Given this list of marker genes SMS, BAP1, PEPD, SCARF2, SPART, ACSL4, SDHD, LRIF1, AP1B1, WNT3, VAC14, WARS1, PROP1, PTDSS1, MET, OCA2, METTL27, PPARG, KRT14, NPR2 (NCBI Gene Id 4882), CHST14, KIDINS220, COQ7, CDK10, TCAP, RTN2, RPL13, CBL, GALNT2, MUC5B (mucin 5B, oligomeric mucus/gel-forming), SPTLC1, MSH4, STX16, MTMR14, SEM1, FMR1, SOS2, ITGB6, PPP2CA, ARSB, MRPS28, HSPG2, MSL3, GMNN, RASGRP1, TCF12, TYROBP, FANCC, HLA-DRB1, WNT4, PALB2, FLVCR1, SLC34A3, SEMA3E, HYAL1, H3-3A, PEX2, PRIM1, SOX4, LIG3, SHANK3, IFT140, DSE, RFWD3, CD244, PEX16, RB1, HPGD, H19, MAPRE2, FTO, QRICH1, SNRPN, CREB3L1, AKT3, NUP133, PTPN22, ASXL1, NEB, MTOR, IL2RA, POC1A, SIAH1, MEGF8, LAMA2, GIPC1, CHRNG, CRLF1, PPP3CA (protein phosphatase 3 catalytic subunit alpha), DUX4, EXOC6B, SULT2B1, UBAP2L, PACS1, SOX9, RTEL1, CYP26B1, VPS33A, SETD1B, APC2, NTRK1, CRPPA, RNF216, NHS, ADAMTS10, CD96 (CD96 molecule), RECQL4, TRIP13, DNAJC30, EPB41L1, GTPBP2, LAMB2, LAMB3, CNOT3, KCTD1, GATA1, SLC35A3, FGFR3 (NCBI Gene Id 55546), TMCO1, PSAP, RNU4ATAC, PHF21A, PDE4D, TP63, SPIDR, AFF2, UFD1, POGLUT1, SPTLC2, BUB1B, LBR, LDB3, COL9A3, GFPT1, BBIP1, SMOC1, BRD4, FIG4, MAP1B, SMAD6, SEMA5A, B2M, DDX6, GJA1, BMPR1A, MYH11, KDSR, KCNN3, GNPTAB, KDM5A, NBAS, ADNP, RPS20, PRX, HSD17B4, COLEC10, TNFRSF11A, ALG6, PIGL, MKRN3, SIK3, CCDC28B, CFTR, TP53RK (TP53 regulating kinase), OSGEP, RPL35A, BMP2, DSTYK, PPP2R3C, TLK2 (NCBI Gene Id 11011), CPLANE1, TUBB2B, PRR12, JAG2, CAST, DYNC2H1 (NCBI Gene Id 79659), ARID1B, PYROXD1, PAFAH1B1, EOGT, ECE1, IDUA, POMT2, FOXP1, IFT74, IFT52, SH2B1, IFT81, MTFMT, KLLN, LTBP4, MIR17HG, LAMC2, FAM149B1, ECEL1, FLNC, MEN1, PEX3, LFNG, SPG11, LUZP1, TBL1XR1, AIP, SLC9A6, GRHL2, POFUT1, MAP3K20, CSGALNACT1, WDR73, TMEM70, B9D1 (B9 domain containing 1), BICRA (NCBI Gene Id 29998), COX4I1, CREBBP, MAPK8IP3, TDO2, TOR1AIP1, CDH3, CTNNB1, SLC10A7, FBLN1, ATG7, CCND2, SC5D, SUFU, RAI1, FBXO38, CLIP2, BGN, KCNJ5, DKK1, ALOX12B, KIAA0586, TNPO3 (transportin 3), CACNA2D1, GYG1, FXN, SMN2, CHD1, PHF6, EIF4H, SMARCB1, FGF9, ARHGAP31, TUBB3, MYPN, PIGF, KIAA0753, PORCN, SLC25A46, TOGARAM1, KRT83, NOG, PIGY, BMPR1B, RNU4-2, MB, KAT6A, POLG2, CTSC, EVC2, TBL2, PIK3CD, CCNQ, BLM, COL25A1, MYL2, EIF2AK3, ZEB2, ASH1L, EXTL3, UPF3B (UPF3B regulator of nonsense mediated mRNA decay), BRF1, NFKBIL1, PPOX, DLX3, LRP4 (NCBI Gene Id 4038), NSD2, TPR, TGFB3, MKKS, SRRM2, TNFRSF1B, RPGRIP1L, POMT1, CEP104, RIT1, IFT172, ARHGEF2 (NCBI Gene Id 9181), TRAPPC9, GNE, GATAD2B, DPAGT1, WAC, FKBP6, SOX11, CSPP1, STIM1 (NCBI Gene Id 6786), RPL35, NUP37, TPM2, EFNB1, ABCA12, EXOSC5, WRAP53, ERCC5, COG8, DNMT3B, BCOR, CEP41 (centrosomal protein 41), SOX18, GNAI1, VPS35L, TRIM32, RELN, GPR101, ANKLE2, STAG1, CNTN1, U2AF2, NR5A1, SASH1, TAF4, SERPINF1, TNR, NEXMIF, SLC12A6, SCN1B, PIGH, KCNK4, NEUROD2, C2CD3, PSMB4, RPS28, AIFM1, MADD, UBR7, HDAC6, TBX1, GJB6, SCN1A, AFF4, TBC1D24, PDK3, VPS33B, DYNC1H1, TGFB1, FGFRL1 (fibroblast growth factor receptor like 1), EBP, PIGS, CLDN16 (claudin 16), RUNX2, SLC5A6, GNB1, PTPN11, NPHP1, RAB11B, HSPB1, RRAS2, SLC35B2, CCDC8, DOCK6, IHH, STUB1, TTN, PYCR2, WDR35, DLG5, GJB4, LORICRIN, SF3B2, CLCN3, ALG12, SLC22A4, PCYT1A, MECOM, BIN1, FTSJ1, BBS12, ACTA1, HNRNPDL, CIBAR1 (NCBI Gene Id 730572), DEAF1, CNTNAP1, SMARCC2, LTBP3, CADM3, BAZ1B, HOXA11, KMT2D, SCN2A, MIR140, KRT5, RPS7, CUL3 (NCBI Gene Id 8452), IPO8, TMEM147, ROBO1, CAMTA1, FLNA, BRCA1, EMD, NEPRO, CPT2, BRIP1, ZSWIM7, EMG1, COL6A3, BPTF, NHP2, NKX2-5, PHYH, SCUBE3, CDKN1C, GP1BB, IQSEC2, NPM1, DPF2, AP1G1, SFRP4, INPPL1, BSCL2, ATRIP, RPGRIP1, SEPTIN9, MYSM1, PTEN, TAT, NOTCH1, ALS2, IRX5, PWAR1, TMEM94, NIN (NCBI Gene Id 57681), FARSA, TRIM37, PRKAR1A, ADAMTSL1, PEX13 (NCBI Gene Id 5194), VPS51, RNF13, CLCN7, GABRA3, ALX1, GMPPA, BPNT2, DHCR24, RAD51, SUPT16H, HDAC8, GUSB, IGF1R, EXOSC2, IFT27, GNAS-AS1, ERCC1, CPLX1, G6PC3, PEX7, SIM1, PARN, RPL9, PEX5, BMP4, IFT122, KDM6A, AMMECR1, ASXL3, SLC35D1, POLG (NCBI Gene Id 5428), COL5A1, LIG4, TBCK, TUBB, NR4A2, COL9A2, SCNM1, TRAPPC2, RPS10 (ribosomal protein S10), KRT6C, SMAD4, SMC5, RETREG1, GLA, PRKCZ, MEGF10, ANAPC1, TXNDC15, TNNT3, CD28, POLR1A, PAPPA2, RASA1, MED12, SAMD9, BANF1, KCNJ11, TYMP, DNM2, UFC1, CTSD, NAA20, KAT6B (lysine acetyltransferase 6B), MTHFS (NCBI Gene Id 10588), SNORD115-1, PDHA1, SIL1 (SIL1 nucleotide exchange factor), TRIM8, SKI, USP9X, SUZ12, DLG4, PIBF1, SRCAP, LAMA5 (laminin subunit alpha 5), PAH, TWIST2, SHOC2, FRA10AC1, KLHL40, MYF6, TMEM231, SERPINB7, ALMS1, VPS37A, AGPS, SGCD, PDXK, CEP57, RPS6KA3, TRAPPC11, KL, NDN, MUSK, SLC25A24, TSEN34, TUBA1A, DLK1, COX14, KIF22, UBE2T, SLX4, FANCG, POP1, OBSCN, NEFL, NCF1, CHN1, ABHD5, GJA8, RPL18, RPL31, MCTP2, ATR, RIN2, SMARCD1, DSC2, NEK1, PEX6, CNOT2, GABBR2, TFG, SH3PXD2B, MYH7, ARL13B, ASAH1, ACTG1, EXT1, DUX4L1, DDHD2, RERE, PEX14, DEPDC5, LEMD3, COPB1, RSPRY1, DHODH (dihydroorotate dehydrogenase (quinone)), EED (NCBI Gene Id 8726), OPA1, MT-TE, CD55, KRT74, PHEX, NEK9, SF3B4, MESP2, CHUK, GPR35, MACROH2A1, GRIN1, YY1AP1, KRT6A, ATP6AP2 (NCBI Gene Id 95880), DYNC2LI1, TRRAP, PRKG2, HYLS1 (NCBI Gene Id 50957), CST6, DPM1, PKP1, GNAQ, EFL1, KIF7, MEFV, ITGA7, BMP15, WNT10A, PRKACB, FANCD2 (FA complementation group D2), TNFRSF11B, HMBS, PEX1, PTPN6, SPTAN1, MCOLN1, ABCA3, ASPH, SEMA4D, GLMN, HIC1, CCDC88A, CRKL, SLCO2A1, HESX1, KPTN, RPS27, COL27A1, CD4, PPP1R13L, GSC, MORC2, KIAA0319L, DSP, XYLT2, SBDS (SBDS ribosome maturation factor), WNK3, ALDH6A1, PI4KA, DYNLT2B, CDK5, POLRMT, DCTN1, PAK3, ARCN1, TBX4, KDF1, LAGE3, AP4M1, BTRC (NCBI Gene Id 8945), BRAF, GRIK2, GPKOW, SLC52A2, SDHB, SP7, POLA1, STAG2, HOXA13, ADAMTS17, REEP1, PLEKHG5, INPP5E, MYLK, NELFA, PPP2R1A, CLDN11, NUP107, RAC1, ATP6V0A2, TFE3, KLHL41, GARS1, AFF3, RAB34 (NCBI Gene Id 83871), NXN, SETD5, CDC6, COL12A1, FBXW4, SMN1 (NCBI Gene Id 91918), CCN6, NEDD4L, GPC3, SIN3A, ZSWIM6, SEC24C, RNF2, TBC1D2B, YWHAE, SOST, SLC6A9, RAB3GAP2, MBTPS1, EGR2, TIMM8A, B4GALT7, SGCG, PRKD1, MTX2, LMBRD2, HIRA, TRPM3, KCNAB2, PSENEN, SNIP1, BUB1, SLURP1, CTNND2, PIK3R2, CCDC32, ITGB4 (NCBI Gene Id 3691), GJB3, ADAMTSL2, LZTR1, PKDCC, ASPN, IFT80, SACS, TOE1, RAB33B, COL6A2, CD247, CHRNE, PPP1CB (NCBI Gene Id 5500), RTL1, HARS1, RAPSN, MAN1B1, TGM1, GALC, TRAF7, KDM4B, GNAS, EFEMP1, MYCN, MMP9, TFAP2A, NEFH, CLPB, LIFR, LTBP1, TGM5, ASNS, ATP2A2, FANCM, PNPLA1, KIF15 (kinesin family member 15), KCNJ8, CDH11, FGFR1, MST1, PUM1, TBCE, YY1, MYMK, PRKAR1B, TPM3, HMGA2, TOR1A, VPS37D, POR, ZNF462, CWC27, EPS15L1, EP300, CDKL5, BUD23, ZNF668, SYNE1, HUWE1, EXT2, GORAB, LETM1, AKT1, CENPE, DMP1, PLOD1, FOXP2, PDE6D, TWNK, GHR, WDR11, NALCN, ZNF141, SCAPER, DST, PHIP, BMP6, FERMT1, DLX4, ERCC2, NKAP, PIGG, JPH1, DNA2, SHOX, KLF13, SATB1, ALDH18A1, CDK19, PMM2, GJB2, PTH1R, MOGS, NARS1, LRBA, RPL8, COL9A1, PEX10, ZIC1, LYSET, CHST3, TRIO, PRG4, ZMYM3, SMC3, WDPCP, H4C3, MPZ, ALX3, IL2RB, APC, ATP11A, IARS1, GDAP1, PIGP, NUP88, ESCO2, NOTCH2NLC, DVL3, EFEMP2, EIF2S3, SLC9A1, LZTFL1, WIPI2, IRF6, JARID2, SPRTN, CITED2 (Cbp/p300 interacting transactivator with Glu/Asp rich carboxy-terminal domain 2, NCBI Gene Id 154106), DLL3, SLC25A4, FBXL3, SIGMAR1, SNRPB, LIPE, MTPAP, DPYD, SCN9A, UNC80, MAGEL2, PIK3R1, TBX2, SLC34A2, FANCE, ALG9, HEPHL1, GDF5, ATAD1, RFX7, SMARCA4, CDC45, RPS23, USB1, BBS1, PGM2L1, TSEN54, OBSL1, RASA2, CEP19, MATR3, DLL4, ORC1, SFTPC (NCBI Gene Id 6440), SCN4A, RIGI, YRDC, IFT56, PLAA, RPL5, WASHC5, TLL1, RSPO2, PEX26, NSD1, CEP290, HHAT, GABRD, CAVIN1, VCP, RAD21, WWOX, KNSTRN, FCGR2A, ACAN, NRAS, IL11RA, NOTCH2, CCNK, CAV1, MARS1, GAN, CASZ1, EIF2AK4, ACTL6B, COL2A1, SPRED2, KDM1A, LMNA, AEBP1, MAP2K2, SEPSECS (NCBI Gene Id 51091), TTC21B, INTU (NCBI Gene Id 27152), L1CAM, NDUFB11, EFTUD2 (elongation factor Tu GTP binding domain containing 2), TCF4, LRP5, PEX12, KRT6B, HNRNPA1, KANSL1, FKRP, CDSN, CYP27A1, FLG, PITX1, POMP, FGD4, SBF2, TRMT10A, KCNE5, KRT85, SOX5, NDRG1, CYP4F22, AGO2, FIBP, GNAO1, MMP1, PIGB, SFTPA1, SPECC1L, SELENON, ALG13, AGA, MPV17, ZDHHC9, NAA60, ERF, DYNC2I2, COG4, HIVEP2, SMAD3, ORC4, PLOD3, ERI1, AK9, BBS2, COLEC11, ACVRL1, MAP3K7, UFSP2, SLC6A17, ARL6IP6, WLS, RECQL, H4C9, TMEM67, MYH8, RYR3 (NCBI Gene Id 6263), MEG3, SVBP, HMGCR, TPRKB, ANO5, USP7, SYNE2, NFIX, TMEM216, BAG3, PRRT2, RREB1, ITCH, FANCL, SMO, ROR2 (receptor tyrosine kinase like orphan receptor 2), ZNF292, TBR1, MAF, TRPS1, SOX6, NAA10, DLX6, PGAP2, IKBKG, LAMA3, MAT2A, IGF2, CHD7, FBN2, CHRNA1, FBXO28, PWRN1, SLC39A8, FANCI, PYCR1, CTSK, DPYS, ARX, PIGQ, GLB1, KCNH1, ARVCF, GATA4 (NCBI Gene Id 2626), RBM8A, MITF, HOXD13, NUP85, VWA1, KDELR2, LMX1B, PLIN4, COL7A1, SMAD2, SRY, DNM1L, TRPV4, KMT2A, CFAP418, RUSC2, LAS1L, ITPR3, GABBR1, RPL10, ADGRG6, POLR3H, TWIST1, WDR37, MRPS22, PROKR2, IFIH1, BMP1, TBX3, CHSY1, FDFT1, AGPAT2, POU1F1, ARID2, FOXE3, PIGO, HINT1, ANKRD55, KRAS, TFAP2B, ZNF469, RPL15, RMRP, GLE1, LARS1, TYMS, SPEN, OPA3, PHF8, RUBCN, SLC26A2, HNRNPH2, DPP9, KATNIP, CEP120, REV3L, PNPLA6, FRG1, EHMT1, RPS26, CACNA1A, GATA6, FANCA, DYNC2I1, ZBTB20, MECP2, HYOU1, AQP5, KDM6B, HFE, IDS, PLEC (plectin), ADH5, MAX, GPC4, FGFR2, FKBP10, LMBR1 (NCBI Gene Id 85501), MAPK1, WNK1, CUL4B, ATP7A, PAICS, TINF2, BBS5, CHRND, CBY1, RPL27, KRT1, MSX2, PAX3, FZD2, NCKAP1L, ABCC9, NF1, IRF5, SPARC, TGFBR2, SPTBN1, FN1, NSUN2, NOD2, DYSF, CPOX, TREX1, GNA11, CLCN5, KIF5C, PIK3C2A, GMPPB, CKAP2L, ERCC6, HK1, RAB3GAP1, MLIP, IL6ST, CHD8, PLAG1, FAT4, PIGV, RHBDF2, PIK3CA, HEPACAM (NCBI Gene Id 220296), SLC39A13, ADAMTS15, TCTN3, RIPK4, IQCE, ENPP1, TGFBR1, OTUD5, GTF2I, CWF19L1, SNAP29, FBLN5, CSNK2A1, GJB1, GNB4, TGDS, PTF1A, SVIL (NCBI Gene Id 6840), TMEM270, CIITA, COASY, SLC29A3, KRT10, PTPRF, DPH2, NAA80, MFAP5, NKX2-6, CEP152, EDA2R, ANXA11, TRPV3, IGF1, OCRL, DMXL2, DGCR2, EMILIN1, PRMT7, KLHL15, EIF4A3, TAPT1, GNPNAT1, TBX22, CTSB, GPC6, STN1, CAV3, BLTP1, VPS13B, CTC1, ZNF699, GATA2, KLHL24, ADAMTS3, SATB2, TMEM237, MTM1, INSR, TNNI2, EYA1, RAB23, GRB10, CYP7B1, DVL1, NFASC, RBM28 (NCBI Gene Id 55131), GATA5, USF3, SIK1, CANT1, EDA, KIFBP, MMP13, UBE4B, OTUD6B (OTU deubiquitinase 6B), DONSON, H3-3B, MYBPC1, JAG1, PHOX2A, NTNG1, TIA1, NKX3-2, STXBP1, IFITM5, STAMBP, KIF21A, NIPBL, COL14A1, C19orf12, HES7, PCDHGC4, PRDM5, MATN3, SLC9A7, DSG1, DOK7 (NCBI Gene Id 619409), FGF16, MT-CO3, ATL3, RAC3, SHMT2, NPR3, DGCR8, ASXL2, IL21, TASP1, CLP1, COL1A2, ZNF423 (zinc finger protein 423), PGAP3, PIGT, MYOD1, SHH, ADA2, SPEG, NONO, FILIP1, DHX16, NOP10, ACTB, XYLT1, SLC35C1, TMEM138, LMNB2, RPS15A, PEX11B, DYM (NCBI Gene Id 54808), P3H1, TERC, TRAIP, ADSS1, GNB2, COL11A1, SDHC, B3GALT6, B3GAT3, CLIC2, CDC42BPB, SFTPA2, SUCLG1, PMP22, KMT2E, PDPN, GGCX, FAM50A, CERS3, PRKDC (protein kinase, DNA-activated, catalytic subunit), ADAT3, TCTN2, HTT, CTLA4 (NCBI Gene Id 3411), PDE3A, WASF1, EZH2, PSTPIP1, COL11A2, KLK11, ATP13A2, SMARCA2, RYR1 (NCBI Gene Id 906), ELN, GRM7, MFN2, GPX4, MEF2C, MYH2, CYP27B1 (cytochrome P450 family 27 subfamily B member 1), NUP188, UBE3B, HRAS, ZMPSTE24, SCYL2, BUB3, GDF1, KATNB1, ALG14, DHCR7, ST3GAL5, KY, MRAS, SLC18A3, ATRX, ESS2, ALG2, CNOT1, SMCHD1, RTTN, DOCK3, TBX5, ERGIC1, COX7B, HS2ST1, AHDC1, KANK2, MED13L, ARPC4, CDC42, SPG7, GNS, SLC52A3, PNPLA2, ZC4H2, SCLT1, SNUPN, WDR4, WDR81, CC2D2A, TTC8, COG6, DNAJB6, GLYCTK, COL13A1, CHRNB1, TMEM53, CHST11, ACBD6, RPS24, ZMYM2, WNT5A, IDH2, EMC1, GLI1, CAPN3, FGF10, ALOXE3, SON, PSMC3IP, ADAMTS2, WFS1, LOX, SERPINA12, VDR, WRN, CFL2, BICD2, EXOSC9, COMT, SLC32A1, KBTBD13, TSEN15, GTF2IRD1, COL5A2 (NCBI Gene Id 1290), FANCB (FA complementation group B), IARS2, SLC25A12, RPL11, TAF6, ARMC9, FGD1, NLRP3, RPS29, MED25, PCNT, HSPB3, TUFT1, TOPORS, PPM1D, MGAT2, KRT17, ACTG2, DMD, HECTD4 (HECT domain E3 ubiquitin protein ligase 4), CDT1, AAGAB, RAF1, ATN1, TNNT1, MKS1, ERLIN2, SYT2, ARL3, FHL1, CUL7, WNT7A, ATP2B1, GLI3, CRIPT, TMEM222, LARS2, SLC2A10, NECTIN1, ITPR1, FGF23, SNORD116-1, RBPJ, SLC25A21, THSD4, GDF11, IL10, STS, COL10A1, DHPS, HEY2, TMEM218, MME, MMP23B, COL1A1, ARID1A, ALDH1A2, SOS1, SALL1, SMARCAD1, MBTPS2, PCGF2, DNAJC21, CHRNA7, ATP6V1B2, B9D2, TGFB2, SEC23B, PAX1, HERC1, SLC35A2, ZNHIT3, NGLY1, MAP2K1, PTCH1, MIA3, DPYSL5, PNKP, KCNJ2, RIPPLY2, MYL11, FRAS1, COL17A1 (NCBI Gene Id 7828), CHD4, SMG9, ABCC8, AGGF1, MBD5, BBS7, RAD51C, SPRED1, OFD1, WNT10B, SGCB, C1R, ASCC3, PLXND1, MT-CO1, WDR19, DACT1, KCNK9, FLNB, FANCF, BCORL1, IGHMBP2, KMT2C, TERT, SQSTM1 (NCBI Gene Id 94002), MYOT, CHCHD10, HNRNPR, THOC2, PTCH2, UROS, MCM3AP, PPIB, SMPX (small muscle protein X-linked), CEP55, TELO2, JUP, CIC, ARSL, ANKRD11, RAB18 (RAB18, member RAS oncogene family), SRD5A3, SALL4, CAPRIN1, ALG3, POLR3GL, PSMB8, NLRP1, KIF1A, GALNS, CILK1, CARD14, DPH1, NIPAL4, LRP12, CYP2R1, POLR3A, CSTA, TRIP11, MAD2L2, CBS (NCBI Gene Id 875), PHGDH, ESAM, CRYAB, BRCA2, FBXO11, HBB, MMP14, NDE1, CIB1, RPS17, KIF5A, STK11, CRELD1, GNPAT, UBR1, SMC1A, TCF20, CASK, DHX30, MAN2C1, ATP7B, MEIS2, TRIM2, PLOD2 (procollagen-lysine,2-oxoglutarate 5-dioxygenase 2), ABL1, FOS, LIMK1, SET, FBXW11, ACTA2, INF2, LPIN1, MMP2, RLIM, AGRN, PUF60, IVNS1ABP (influenza virus NS1A binding protein), KRT16, ACP5, LSS, RPL26, SORD, P4HTM (NCBI Gene Id 54681), IFT57, LGI4, EIF4A2, KLHL9, NANS, ATL1, TMEM43, TBX15, COG7 (NCBI Gene Id 91949), CTDP1, PACS2, TK2, MTR, GJA5, FKTN, TMEM107, TSR2, NPAP1, UBE3A, COL6A1, FBN1, HNRNPK, NARS2, SETD2, OGT, TCTN1, IFT43, TRPM4, CHD6, CEP126, ERCC8, CCN2, DDR2, DCHS1, CAMK2G, PDGFRB, COG1, TONSL, EVC, ZFPM2, AMER1, PSMD12, LARGE1, BBS9, CBFB, POGZ, SETBP1, FSHR, MED12L, ATP6V1E1, DIS3L2, BNC1 (NCBI Gene Id 646), SLC25A22, XRCC4, AAAS, UBA1, CCDC22, PPP1R15B, HERC2, COL3A1, PTHLH, MAFB, KIT, SPOP, DKC1, HNRNPH1, STAT4, PRKACA, XK, LTBP2, ODC1, IDH1, MAPT, ZIC3, RPS19, NR2F1, PIGW, HCCS, XRCC2, MASP1, PRDM16, H4C5, BRAT1, GON7 (GON7 subunit of KEOPS complex), LONP1, RBM10, GLDN, PTRH2, EN1, LHX4, NSDHL, RILPL1, MLXIPL, JMJD1C, ZFX, SCO2, KDR, DDX59, ATP6V1A, RRM2B, PTPN2, COLQ, FLII, AHSG, DYRK1A, SUMF1, ACOX1, BCR, KRT2, HDAC4, CTU2 (cytosolic thiouridylase subunit 2), FAM13A, ANTXR2, NECTIN4, MYL1, KAT8 (NCBI Gene Id 88034), TOMM7 (translocase of outer mitochondrial membrane 7), MYMX, PIEZO2, DLX5, PIGN, MYH3, ERCC4, SDR9C7, PIGA, FLT4, UBA2, ACVR1, YARS1, KCNA1, PERP, B3GLCT, SMARCE1, PUS1, ORC6, COG5, CCR6, GBF1, HACD1, RFC2, ABCC6, DNMT3A, ARL6, GNPTG, GTF2IRD2, COMP, RBBP8, CTBP1, LMOD3, PPP1R21, LHX3, KDM5C, MGP, ATP1A2, BBS4, PEX19, KDM5B, SMPD4, FLI1, CTCF, ZMIZ1, ALX4, PRKG1, RFT1, RSPO1, SGCA, BHLHA9, STX1A, DPH5, DDX11, KRT9, CCBE1, KMT2B, CCDC47, PQBP1, CLCF1, SDCCAG8, AUTS2 (activator of transcription and developmental regulator AUTS2), AHI1, TSEN2, HEATR3, DGCR6, EBF3 (NCBI Gene Id 276717), WDR26, RRAS, KIAA0825, GLI2, ZNF407, BBS10, PLK4, SLC4A10, here is a description of the gene set: species: Homo sapiens An abnormality of the arm. Abnormality of the upper limb Human Gene Set: HP_ABNORMALITY_OF_THE_UPPER_LIMB